Given this list of marker genes PLCB1, TSHZ1, TMF1, VKORC1L1, CSAD, PINK1, C5orf22, DIDO1, ZMYM2, CLDN8, CNOT6, CADM1, ABCA1, BAZ1A, PRRC1, SLC44A1, SPAG9, CPNE4, SLC44A5, ROBO2, INTS2, FAM199X, BRWD3, MBNL3, PTPN22, RRAS2, PKN2, SLC25A2, SAMD4B, SPART, ZNF275, RSBN1, STC1, PPP1R1C, EIF5A2, KRAS, TMEM167A, PTPRZ1, PHF6, CREBRF (CREB3 regulatory factor), NXT2, ALG6, HOOK1, PCNX1 (pecanex 1), DENR, EPG5, IVNS1ABP, RIN2, KCNT2, SFRP5, ZMYM5, UBR3, HNRNPH3, BET1, AGFG1, SELENOI, SLC2A3, SEMA4D, NKAPL, RMND5A, NAAA, MAGI2, MIA2, HMGA2, FCHO2 (NCBI Gene Id 115548), ACBD5, TBC1D4, DIAPH3, ECH1, NALF1, GPD1L, DESI2, SEPTIN8, LRP12, ZNF793, CLASP2, ALCAM (NCBI Gene Id 214), RFX3, DDX21, CRY1, ELAPOR2, SCN3A, MTMR10, PALM2AKAP2, MLLT3, LETM2, CEPT1, TSPAN9, GPR155, STAG1, TFAP2C, ZC3H6, TRPC4AP, RNF141, PLPPR4, SMAD4, PCGF3, CNR1, SGCD, RORA, MYC, ELOVL7, PICALM, BSDC1, CEP192, MIB1, FOXQ1, COL19A1, C3orf80, EXD1, PNPLA4, ABI1, SOCS1, LPP, CMC1, DNAJC7, ROBO1, DCUN1D1, GTF2A1, LMBR1, ATG5, ZCCHC14, SOX5, SLC25A33, STXBP5, NLGN1 (NCBI Gene Id 22871), ADPRM, SYTL2, SMARCAD1, ELAVL2, BCOR, SRCIN1, BNC2, KIAA1210, IFT56, KIAA0408, KHDC4, SPRED1, ELP4, P2RY12, AAK1, ANKRD17, HLTF, UBE3B, SKIL, GNA13, IGFBP3, MTMR7, HAS2 (NCBI Gene Id 3037), C1D, STON2, BCLAF3, GRIA2, ATP11A (ATPase phospholipid transporting 11A), SLC25A37, SPAG16, ZNF709, MARCHF5, RC3H1, MINDY2 (NCBI Gene Id 54629), C21orf91, CDK17, ACTR10, ARHGAP5, SPIRE1, MAK16, HNF1A, FBXO22, ZNF274, PRDM10, C6orf120, FAM83B, SUMO2, TJP1 (tight junction protein 1), AVIL, STK38, MEGF10 (NCBI Gene Id 84466), CDH6, PCDH11X, GUCY1A1, PMEPA1, CNTN1, DNM1L, NFX1, CNKSR2, CD2AP, RRP1B (NCBI Gene Id 23076), GXYLT1, CTCF, FBXO33, FAM133A, RSAD2, TBL1XR1, SIRT1, GLS2 (glutaminase 2), ZFHX4, LIG4, RSRC1, BPNT2, TTPA, COG6, SLC15A1, STK38L, EXO1, TENT2, BLTP1, HNF4A, ITIH5, TTC33, SORT1, ERCC6, TAOK1, SNAP91, DNAJB14, PIWIL1, CEP70, VSTM4, RASAL2, DPYD, LMX1A, ATXN3, WDR20, ADD3, FHIP2A, KLHL14, ATP13A3, RAD21, NDUFA10 (NCBI Gene Id 4705), HAPLN1 (hyaluronan and proteoglycan link protein 1), SDC2, VGLL3, ANKRD20A4P, PARD6B, SLC4A4, TADA1, ZMYND8, LSM12, UBE2D1, PRDM15, ATXN7L2, XPR1, DCAF4L2, SGPP1, TMX3, PDCL, ATF7IP, PCM1, GPD2, LEPROT (leptin receptor overlapping transcript), DCP2, CCNG1, PLCB3, ADAM23, ZFP36L1, CDK6 (NCBI Gene Id 1021), MAP3K9, ZNF148, ZNF117, NEDD1, ABHD18, FAM135A, PSD3, KLF6, PDE7B, MBTD1, TENM3, KATNAL1, SEPTIN14, ZNF57, MMD, KCNQ5, CASP8, STRBP, SFRP2, BMPR2, CLOCK, METTL15, PRRG3, BIRC3, AMN1, PRXL2C, APC, ELOC, CACNA2D1, KLHDC1, PPP3R1, SEC62, SMARCA5, MSMO1, SPIC (NCBI Gene Id 121599), CXCL8, CNGB3, ZFAND3, CNBP, RAP2C, RIC8B, CHSY3, TNFRSF12A, C1orf21, WDR5B, ZKSCAN7, ARL5B, REEP3, TRA2A, ZCCHC10, CEP97, REL, MDM1 (Mdm1 nuclear protein), CSDE1, NHLRC2, YWHAZ, ETV1, MED14, WNT2, FBXO48, LYRM7, CCNT2, ARAP2, LRIF1, SFT2D1, KLHL4, GCH1, SCN3B, CNTN3, MYO1D, CACNA1B, PLAGL1, SAMD8, TCF21, LIMCH1, SGMS1, PUM2, INSM1, PRP4K, TCEA1, CEP290, PHTF2, ZBTB44 (zinc finger and BTB domain containing 44), FZD6, CPED1, CHD9, OTULINL, ZBTB6, RBBP7, ABCD4, CCNH, SMNDC1, SORBS1, STAU1, MAP4K3, PGR, CCNG2, CLHC1, FERMT2, PCDH9, here is a description of the gene set: Genes predicted to be targets of miRBase v22 microRNA hsa-miR-548at-5p in miRDB v6.0 with MirTarget v4 prediction scores > 80 (high confidence targets). Human Gene Set: MIR548AT_5P from publication Chen Y, Wang X (PMID 31504780) species: Homo sapiens